The following is a description of a gene set: part of: SARS-CoV-2-host interactions species: Homo sapiens SARS-CoV-2 encodes several proteins that have been implicated in shutting off host expression (Banerjee AK et al. 2020; Finkel Y et al. 2021). 2020), SARS-CoV-2 nsp16-mediated disruption of global mRNA splicing via binding to the 5′ splice site recognition sequence of U1 snRNA and the branchpoint recognition site of U2 snRNA, both parts of the spliceosome, and SARS-CoV-2 nsp8, nsp9-mediated suppression of protein integration into the cell membrane. Reactome Pathway: SARS-CoV-2 modulates host translation machinery, and this is the list of marker genes: RPS4X, SNRPB, GEMIN8, RPS18, FAU, RPS3, RPS28 (NCBI Gene Id 6234), RPS11, GEMIN2, RPS17, RPS4Y2, RPSA, RPS14, GEMIN7 (NCBI Gene Id 79760), RPS27A, RPS27, RPS5, RPS26 (ribosomal protein S26), 18S rRNA, SNRPD2, 7SL RNA (ENSG00000222639), rep, RPS25, RPS20, SNRPD1, RPS16, RPS9, SMN1, RPS15, DDX20, RPS10, SNRPF, RPS21, RPS15A, RPS24, SNRPD3, GEMIN6, GEMIN5, RPS19 (ribosomal protein S19), SNRPE, RPS13, RPS2, RPS29, GEMIN4, RPS23, RPS3A, RPS8, SNRPG, 7SL RNA (ENSG00000222619), pp1a, RPS4Y1, RPS6, RPS7, RPS12, RPS27L